The following is a description of a gene set: Reactome Pathway: Mitochondrial translation initiation Translation initiates with the mitochondrial mRNA binding the 28S subunit:MTIF3 (28S subunit:IF-3Mt, 28S subunit:IF3mt) complex together with MTIF2:GTP (IF-2Mt:GTP, IF2mt:GTP). As inferred from bovine homologs, the 28S subunit, 39S subunit, and 55S holoribosome associate with the matrix-side face of the inner membrane and the translation products are inserted into the inner membrane as translation occurs. Mitochondrial mRNAs have either no untranslated leader or short leaders of 1-3 nucleotides, with the exception of the 2 bicistronic transcripts, RNA7 and RNA14, which have overlapping orfs that encode ND4L/ND4 and ATP8/ATP6 respectively.. Binding of N-formylmethionine-tRNA to the start codon results in a stable complex between the mRNA and the 28S subunit while absence of a start codon at the 5' end of the mRNA causes the mRNA to slide though the 28S subunit and eventually dissociate. The 39S subunit then binds the 28S subunit:mRNA complex, GTP is hydrolyzed, and the initiation factors MTIF3 and MTIF2:GDP dissociate. species: Homo sapiens part of: Mitochondrial translation, and this is the list of marker genes: MT-CYB (NCBI Gene Id 4519), MRPL4, MRPS15, MRPL57, MRPL2, MRPL47, MRPL42, MT-TV, MRPL40, MRPL54, MT-CO1, MRPL18, MRPL20, MRPS9 (mitochondrial ribosomal protein S9), MRPL52, MRPL22, MRPL30, MRPL43, MRPL19, MRPL45, MT-RNR1, MRPL1, MT-ATP6, AURKAIP1, MT-ND6, MRPS18C, MRPS17 (mitochondrial ribosomal protein S17), MRPL3, MRPL10, MRPS6, MRPS25, MRPL21, DAP3, MRPL32 (NCBI Gene Id 64983), MRPL41, ERAL1, MRPL35, MT-ND2, MRPS2, CHCHD1, MT-ND5, MRPL28, MT-RNR2, MRPL16, MRPL17, MRPL58, MRPS31, MRPL11, MRPS34, MRPL9, MRPS5 (mitochondrial ribosomal protein S5), MRPL53, MT-CO2, MRPL24, MRPS7, MRPL13, MT-CO3, MRPL39, MRPL46 (mitochondrial ribosomal protein L46), MRPS16, MRPL12, MRPL44, MRPS14, MRPL15, MTIF3, GADD45GIP1, MRPL33, MRPS10, MRPS33, MRPS30, MRPL37, OXA1L, KGD4, MRPS21, MRPS18B, MT-ATP8, MT-ND4, MRPL38, MRPS18A, MRPL49, MRPS26, MRPS35, MT-ND3, MRPL55, MRPL27, MTFMT, MRPL34, MRPL48, MTIF2, MRPL14, MT-ND4L, MRPS12, PTCD3, MRPS22, MRPL50, MRPS28 (NCBI Gene Id 64947), MRPS23, MT-ND1, MRPL51, MRPS24, MRPS27, MRPS11, MRPL23, MRPL36